Given this list of marker genes GPRIN3, WBP1, S100A10, ANKRD46, TRMT112, NAA20 (NCBI Gene Id 51126), SUPT4H1, ZNF451, PYGL, GSTT2, CST3, CORO7, MCUB, ACOT9, LRWD1, ATP5IF1, C2CD5, ADSS2, NEFL, COQ8A, GLIPR2, WRN, TRMT13, HSCB, SKAP1, B3GNT5, PIK3R5, CARD6 (NCBI Gene Id 84674), MAPRE3, PLP2 (proteolipid protein 2), PHAF1, WLS, RPS25, TNRC6B, HEXB, SLC37A3, PCGF1, TSPAN3, AQP9, AQP3, ARID5B, ABTB3, ARHGEF3, DECR2, SPOP, EZH1, ABHD18, WDR44, SIGIRR, ZNF229, TTYH3, EPS15, SFR1, CNN2, ANKH, PCNT, ZC3H12D, KCNJ8, STAG1 (STAG1 cohesin complex component), LY9, KLF13, SH3BGRL, ARID1B, KLF6, FAM78A, ENTREP3, C14orf39 (NCBI Gene Id 317761), REXO5, PPP4R3A, ARHGAP15, LYST, MZT1, PPP2CB, GPR68, MSH2, SELENOP, FBXW7, TNFSF4, EPB41, MYO1F, SPATA6, PLEC, SUPT16H, DCLK3, SUSD1, NME3, TMEM35B, PLAC8, IFT140, HLA-DOA, PITPNC1, INSIG2, SNW1, ACSS1, UBAC2, TXNDC12, KAT2B, C9orf152, CDKN2AIPNL, ST3GAL6, ARK2C, LTB, DDC, TES, RNASEH2A (NCBI Gene Id 10535), DPP4, SUN2, CDK19, IFT46, CTSW, CAV2, PPT1, NSD3, B4GALT1, RDM1, DEPDC1B, LCP2, CPNE3, UROD, LYPD6B, USP48, CPNE5, LRRC8C, RNF19B, CD84, TCF20, AKAP13, ICAM2, GMFG, ICOS, TNFAIP3, CENPC, FIS1, IFNGR1, NR2E3, KLHL4, FXYD5, NIN, REEP3, ABCA1, SSBP2, INF2 (NCBI Gene Id 84800), LXN, CBX3, SUGT1, DKKL1, PRSS12, CTSC, DNAJC9, KCNMB4, PURG, ZC2HC1A, RUNX3, VPS13B, CNP, DONSON, ZNF141, CD2, CRLF3, RAD52, PTPN18, LNPEP, ELF2, CDC25B, SELL, UBE2B, CXCR6, GIMAP7, RPL37A, EVI2B, STK26, AIDA, SERINC3, BACH2, TASL, TRIM59, GNAQ, DGKA, ARL6IP1, GAB3, VPS54, ACAT2, METTL14, PLSCR4, FKBP1A, ARAP3, TAB2, MAP1LC3B, TMEM242, TP53I13, DIPK2A, SPO11, POLM (NCBI Gene Id 27434), SRI, PIN4, INSR, FYB1, CLDND1, MLLT3, here is a description of the gene set: Genes down-regulated in endothelial cells: untreated versus IFNG. Human Gene Set: GSE6092_UNSTIM_VS_IFNG_STIM_ENDOTHELIAL_CELL_DN Borrelia burgdorferi, the agent of Lyme disease, promotes pro-inflammatory changes in endothelium that lead to the recruitment of leukocytes. The host immune response to infection results in increased levels of IFN-gamma in the serum and lesions of Lyme disease patients that correlate with greater severity of disease. Therefore, the effect of IFN-gamma on the gene expression profile of primary human endothelial cells exposed to B. burgdorferi was determined. B. burgdorferi and IFN-gamma synergistically augmented the expression of genes, seven of which encode chemokines. Six of these (CCL7, CCL8, CX3CL1, CXCL9, CXCL10, and CXCL11) attract T lymphocytes, and one (CXCL2) is specific for neutrophils. Synergistic production of the attractants for T cells was confirmed at the protein level. IL-1beta, TNF-alpha, and LPS also cooperated with IFN-gamma to induce synergistic production of CXCL10 by endothelium, indicating that IFN-gamma potentiates inflammation in concert with a variety of mediators. An in vitro model of the blood vessel wall revealed that an increased number of human T lymphocytes traversed endothelium exposed to B. burgdorferi and IFN-gamma, as compared to unstimulated endothelial monolayers. In contrast, addition of IFN-gamma diminished the migration of neutrophils across B. burgdorferi-activated endothelium. IFN-gamma thus alters gene expression by endothelium exposed to B. burgdorferi in a manner that promotes recruitment of T cells and suppresses that of neutrophils. This modulation may facilitate the development of chronic inflammatory lesions in Lyme disease. from publication Dame TM, Orenzoff BL, Palmer LE, Furie MB (PMID 17202382) studied in species Homo sapiens